Given this list of marker genes VLDLR, KIF1A, EEF2K, CAPRIN1, RELN, STAU2, ARHGAP33, CDKL3, LRRK2, FBXW8, WNT7A, MAP2, MAP6, CTNNA2, ITPKA, MEF2A, RAP2A, NLGN1, DTNBP1, ABITRAM, TNIK, FYN, TRPC6, DCDC2 (NCBI Gene Id 606719), RERE, CFL1, TMEM106B, WASL, CDK5R1, SLC30A1, CC2D1A, ADGRB3, CDK5, NFATC4, MAPK8IP2, LRP8 (LDL receptor related protein 8), SLITRK5, SLC11A2, PQBP1, CDKL5, TLX2, EPHB3, SHANK3, DHX36, SS18L1, DOCK10, ANKRD27, LRP4, PPP3CA, GSK3B, NSMF, PAK3, TBC1D24, GORASP1, NRP1, EPHB1, BTBD3, SULT4A1, PARP6, KLF7, NGEF, YWHAH, KNDC1, ABI2, NEDD4 (NCBI Gene Id 4734), PDLIM5, SIPA1L1, PREX2, ZDHHC15, NEDD4L, ATG16L1, RAC1, CUL7, CUX2, SHANK1, PTEN, ARHGAP44, BAIAP2, DBN1, HDAC6, NR2E1, GPRASP3, SEMA4D, RAB21, NEUROG3, DSCAM, CDC42, ABI1, MINK1, FZD4, DPYSL5, RAPGEF2 (Rap guanine nucleotide exchange factor 2), EPHB2, CHRNA3, SKOR2, CHRNA7, DVL1, TRAK2, TANC2, CUX1, EPHA4, PPFIA2, TPBG (NCBI Gene Id 7162), PAFAH1B1, IGF2BP1, DIP2A, STK11, TRPC5, SEMA3A, ATP7A, PHACTR1, DLG4, ITGB1, PICALM, SARM1, CAPRIN2, LZTS3, HECW2, HECW1, HPRT1, ELAVL4, CAMK2B, SRCIN1, SDC2 (NCBI Gene Id 6383), CELSR2, CTNND2, TAOK2 (NCBI Gene Id 9344), LZTS1, FARP1, ANAPC2, ZNF365, KIDINS220, NUMBL, ABI3, OBSL1, EFNA1, ARMCX5-GPRASP2, CHRNB2, PTN, IL1RAPL1, TRAK1, PTPRD, ARC, here is a description of the gene set: The process in which the anatomical structures of a dendrite are generated and organized. studied in species Homo sapiens Human Gene Set: GOBP_DENDRITE_MORPHOGENESIS